The following is a description of a gene set: Mouse Gene Set: GOCC_HOST_CELLULAR_COMPONENT species: Mus musculus Any cellular component of a host cell. The host is an organism in which another organism, for instance a parasite or symbiont, spends part or all of its life cycle and from which it obtains nourishment and/or protection., and this is the list of marker genes: Kpna6, Gbp9, Kpna2, Iigp1, Gbp7, Gbp2, Gbp2b, Gbp6, Gbp3